The following is a description of a gene set: studied in species Homo sapiens Human Gene Set: MODULE_511 Genes in the cancer module 511., and this is the list of marker genes: TMEFF2, SPATA31A7, PCIF1, MAP7D3, LPCAT2, ASPSCR1, NOD2, AIG1, DLGAP3 (DLG associated protein 3), M1AP, MAK, OSBPL10, KCNJ1, PKD2L1, XPR1, TSNAXIP1, SRSF12, CRYBG1, BTG3, LMAN1L, HYAL3, CTAGE1, PSME4, CFAP44, SCPEP1, B3GNT5, KATNAL2, PBX4, RNASE2, PARP8, EAF2, RNF133, SLC38A2, ZBTB3, IPP, BFSP2-AS1, DMRT1, ANKRD2, FBN3